Given this list of marker genes NPPC, BNC1, SIRT2, WEE2, AURKA, NPR2, SHB, here is a description of the gene set: species: Homo sapiens Any process that modulates the frequency, rate or extent of oocyte maturation. Human Gene Set: GOBP_REGULATION_OF_OOCYTE_MATURATION